Given this list of marker genes GRPEL1, HSPA9, TIMM44, TIMM23B, PAM16, TIMM21, TIMM50, SLC25A6, TIMM17A, TIMM17B, TIMM10, DNAJC19, GRPEL2, DNAJC15, ROMO1, TIMM23, here is a description of the gene set: The protein transport machinery of the mitochondrial inner membrane that typically transports proteins that possess a matrix-targeting N-terminal presequence. The TIM23 complex contains three essential Tim proteins: Tim17 and Tim23 are thought to build a preprotein translocation channel while Tim44 interacts transiently with the matrix heat-shock protein Hsp70 to form an ATP-driven import motor. species: Homo sapiens Human Gene Set: GOCC_TIM23_MITOCHONDRIAL_IMPORT_INNER_MEMBRANE_TRANSLOCASE_COMPLEX